Given this list of marker genes DPEP2 (NCBI Gene Id 64174), CYP4F8, CYP4F11, GGT1, LTC4S, CYP4A11, DPEP1, ABCC1, ALOX5, CYP4F2, ALOX5AP, CYP4F22, GGT5, LTA4H, MAPKAPK2, ALOX15, CYP4B1, CYP4A22, PTGR1, CYP4F3, here is a description of the gene set: Reactome Pathway: Synthesis of Leukotrienes (LT) and Eoxins (EX) studied in species Homo sapiens Leukotrienes (LTs) are biologically active molecules formed in response to inflammatory stimuli. They cause contraction of bronchial smooth muscles, stimulation of vascular permeability, and attraction and activation of leukocytes. LTs were discovered in 1938 and were termed the "slow release substance" (SRS) until their structures were determined in 1979 and they were then renamed to leukotrienes. LTs are derived from arachidonate through action by arachidonate 5-lipoxygenase (ALOX5). Cysteinyl leukotrienes (LTC4, LTD4, and LTE4) are generated as products derived from leukotriene A4 (LTA4). Eoxins are generated from leukotrienes (LTs) and resemble cysteinyl leukotrienes but have a different three-dimensional structure (Murphy & Gijon 2007, Hammarstrom 1983, MA.Claesson 2009, Vance & Vance 2008, Buczynski et al. 2009). part of: Arachidonate metabolism